The following is a description of a gene set: studied in species Homo sapiens The process whose specific outcome is the progression of an inner ear receptor cell over time, from its formation to the mature structure. Cell development does not include the steps involved in committing a cell to a specific fate. Human Gene Set: GOBP_INNER_EAR_RECEPTOR_CELL_DEVELOPMENT, and this is the list of marker genes: OTOGL, NHERF1, CLRN1, IFT27, TECTA, ATP8B1, TTC8, GABRB2, HES5, PJVK, SEC24B, IFT88, PDZD7, LHFPL5, PAFAH1B1, REST, MKS1, GABRA5, ELMOD3, USH1C, STRC, GRXCR1, SLITRK6, MYO7A, PLS1, SCRIB, CDH23, ADGRV1, SOD1, TRIP11, TSKU, FZD2, ANKRD24, USH1G, FGFR1, HES1, NAGLU, WHRN, WDPCP, CECR2, TRIOBP, RAC1, VANGL2, SLC4A7, IFT20, GRXCR2, TPRN, SDC4, CLRN2, GABRB3, KCNQ1, TMC1, MINAR2, CTHRC1